The following is a description of a gene set: Mouse Gene Set: GOBP_POSITIVE_REGULATION_OF_BONE_MINERALIZATION species: Mus musculus Any process that activates or increases the frequency, rate or extent of bone mineralization., and this is the list of marker genes: Adrb2, Fam20c, Bmpr1a, Bmp2, Ptn (pleiotrophin), Csf1r, Nell1, Slc20a2, Ccn1, Fgfr3, Kl, Pkdcc, Acvr2b, Acvr1, Wnt4, Tent5a, Asxl2, Adgrv1, Bmp7, Rxrb, Tfap2a, Tmem119, Atp2b1, Ano6, Bmpr1b, P2rx7, Actn3, Osr2, Bmp4, Vdr, Rxra, Fzd9, Pth, Wnt10b, Gpm6b, Cd276, Bmpr2, Ltf, Mef2c (NCBI Gene Id 71350), Alox5, Fbn2, Atraid, Smad3, Isg15, Osr1, Slc8a1, Bmp6, Acvr2a, Mia3